The following is a description of a gene set: Mouse Gene Set: GOBP_REGULATION_OF_PROTEIN_DEPOLYMERIZATION species: Mus musculus Any process that modulates the frequency, rate or extent of protein depolymerization., and this is the list of marker genes: Camsap2, Vil1, Pdxp, Wdr47, Fgf13, Map1s, Cracd, Dbnl, Trim54 (tripartite motif-containing 54), Gas2l2, Twf1, Mtpn (NCBI Gene Id 319218, myotrophin), Eps8, Tpx2, Carmil1, Apc2 (NCBI Gene Id 97679), Scin, Gsn, Capza3, Swap70, Rdx, Kif21a, Lmod3, Plek, Gas2l1, Lmod1, Tmod2, Arpc2 (actin related protein 2/3 complex, subunit 2), Capza2, Plekhh2 (NCBI Gene Id 213556), Spast, Ttbk2, Nav3, Nes, Capzb, Ckap2, Capg, Bmerb1, Shroom2, Apc, Camsap3, Capza1, Hdac6, F2rl1, Eml4, Asph, Arhgef2, Myh9, Sptbn1, Katnb1, Dstn, Lima1, Svil, Diaph3, Bbof1, Camsap1, Capza1b, Mid1, Tmod1, Cfl1, Ccdc88c, Tpm1, Evl, Tmod4, Sptb, Mid1ip1, Add3, Vill, Twf2, Flii, Sptan1, Map1a, Sh3bp1, Carmil2, Actn2, Tmod3, Dmtn, Hdgfl3, Pik3ca, Wdr1, Trpv4, Cib1, Map6d1, Spef1, Specc1l, Map2, Add1, Spta1, Add2, Stmn2, Htr1a, Cfl2, Lmod2, Sema5a, Clasp1, Map1b, Clasp2, Atxn7, Avil, Taok1, Rp1, Aurkb